The following is a description of a gene set: studied in species Homo sapiens Any process that stops, prevents or reduces the frequency, rate or extent of telomere capping. Human Gene Set: GOBP_NEGATIVE_REGULATION_OF_TELOMERE_CAPPING, and this is the list of marker genes: SMG6, TERF2, ERCC1, ERCC4, RAD50, XRCC1, NBN, ATM